The following is a description of a gene set: Mouse Gene Set: GOBP_CELLULAR_RESPONSE_TO_INCREASED_OXYGEN_LEVELS studied in species Mus musculus Any process that results in a change in state or activity of a cell (in terms of movement, secretion, enzyme production, gene expression, etc.) as a result of a stimulus reflecting an increase in the level of oxygen., and this is the list of marker genes: Atp6v0a2, Atp6v1g1, Nox1, Atp6ap1, Atg7, Foxo1, Ccdc115, Tmem199 (NCBI Gene Id 97763), Atp6v0d1, Fas, Cav1, Atp6v1a (ATPase, H+ transporting, lysosomal V1 subunit A)